Given this list of marker genes SLC12A1, SLC10A2, SLC6A4, SLC6A3, SLC6A1, SLC10A1, SLC12A3, SLC16A7, SLC6A11, SLC15A2, SLC15A1, SLC5A5, EBP, SLC16A4, SLC6A2, SLC24A1, SLC34A1 (solute carrier family 34 member 1), SLC16A2, SLC17A2, here is a description of the gene set: Human Gene Set: MODULE_162 species: Homo sapiens Genes in the cancer module 162.